The following is a description of a gene set: Any process that results in a change in state or activity of a cell or an organism (in terms of movement, secretion, enzyme production, gene expression, etc.) as a result of a stimulus from a yeast species. Human Gene Set: GOBP_RESPONSE_TO_YEAST species: Homo sapiens, and this is the list of marker genes: ADM, CRK, CLEC6A, CALCA, TAC1, CAMP, ANG (NCBI Gene Id 283), APP, PLCG2, NCF1, CLEC7A (NCBI Gene Id 64581), ELANE, VIP (NCBI Gene Id 7432), PTX3, NPY (neuropeptide Y), MPO